Given this list of marker genes Ighmbp2, Helb, Ercc2, Twnk, Pif1, Zgrf1, Dna2 (DNA replication helicase/nuclease 2), Ddx11, Brip1, here is a description of the gene set: Unwinding a DNA helix in the 5' to 3' direction, driven by ATP hydrolysis. Mouse Gene Set: GOMF_5_3_DNA_HELICASE_ACTIVITY studied in species Mus musculus